The following is a description of a gene set: Pathway Definition from KEGG: PLK1,AURKB,CDK1 -- NCAPD3,NCAPG2,NCAPH2 studied in species Homo sapiens Human Gene Set: KEGG_MEDICUS_REFERENCE_MODIFYING_OF_CONDENSIN_II_SUBUNITS Modifying of condensin II subunits. Pathway ID: N01499. Pathway type: Reference. Pathway class: nt06512 Chromosome cohesion and segregation., and this is the list of marker genes: NCAPD3, CDK1, NCAPH2, NCAPG2, AURKB (aurora kinase B), PLK1